The following is a description of a gene set: Ankle pain species: Homo sapiens An unpleasant sensation characterized by physical discomfort (such as pricking, throbbing, or aching) localized to the ankle. Human Gene Set: HP_ANKLE_PAIN, and this is the list of marker genes: LEMD3, HYAL1, COMP, MATN3, MAFB, COL11A1